Given this list of marker genes SBF2, GDAP1, CCT5, ATXN1, DHX16, NEFL, HSPB8, VPS13A, RNF170 (NCBI Gene Id 96586), UQCRC1, LMNA, SORD, ATL1, RFC1, SPTLC2, HK1, SPTLC1, MPV17, ATL3, FXN, LITAF, MORC2, TRPV4, NDRG1, here is a description of the gene set: Human Gene Set: HP_DECREASED_AMPLITUDE_OF_SENSORY_ACTION_POTENTIALS A reduction in the amplitude of sensory nerve action potential. This feature is measured by nerve conduction studies. studied in species Homo sapiens Decreased amplitude of sensory action potentials